Given this list of marker genes NLRP3, PYCARD, CARD8, GPSM3, IRGM, here is a description of the gene set: species: Homo sapiens Human Gene Set: KEGG_MEDICUS_REFERENCE_REGULATION_OF_NLRP3_INFLAMMASOME_SIGNALING_PATHWAY_NLRP3_INHIBITION Pathway Definition from KEGG: (CARD8,GPSM3,IRGM,NO) -| (NLRP3+PYCARD) Regulation of NLRP3 inflammasome signaling pathway, NLRP3 inhibition. Pathway ID: N01568. Pathway type: Reference. Pathway class: nt06521 NLR signaling.